Given this list of marker genes USP7, RET, NADK2, FBXO28, CCDC47, MYO9A, COQ2, CDK13, SLC18A3, AGRN, PHOX2B, MAGEL2, PIGT, FGFR3, SLC5A7, ASCL1, PRPS1 (NCBI Gene Id 8254), PLCB4, SNAP25, CACNA1C, ASCC3 (NCBI Gene Id 63921), VAMP1, SYT2, COL13A1, DKK1, CACNA1I, SLC25A1, CHAT, NGLY1, SIM1, LRPPRC, here is a description of the gene set: Human Gene Set: HP_CENTRAL_SLEEP_APNEA Central sleep apnea Sleep apnea results from a temporary loss of the central drive to the muscles responsible for breathing. studied in species Homo sapiens